The following is a description of a gene set: species: Homo sapiens Expressed lower levels of cartilaginous matrix genes and elevated levels of genes involved in the cellular response to ER stress, namely, DDIT3, HSPA5, and ATF5. Low-grade and medium-grade samples contained Chon2 and Chon1 clusters. Chon1 and Chon2 clusters represent early malignant transformation involving activation of the ER stress pathway. The Chon2 cluster is a marker for the malignant transformation of differentiated tumours (consisting of Ben, Low, and Med). Chon2 cluster markers were enriched in response to ER stress (e.g., DDIT3, HSPA5, and TRIB3). The ER stress response identified in cartilage neoplasm appeared to play a role in the pathological process of tumorigenesis but not in normal skeletal development. The Chon2 cluster accumulated an additional copy number gain at chromosome 19. Thirty-three genes, including UBE2S and TRIM28, showed significant copy number gain at this region. The Chon2 signature score was increased along with tumour grades. Human Gene Set: SU_HO_CONV_CENT_CHONDROSARCOMA_C5_CHON2 from publication Su Z, Ho JWK, Yau RCH, Lam YL, Shek TWH, Yeung MCF, Chen H, Oreffo ROC, Cheah KSE, Cheung KSC (PMID 38267611) The transformation of benign lesions to malignant tumours is a crucial aspect of understanding chondrosarcomas, which are malignant cartilage tumours that could develop from benign chondroid lesions. However, the process of malignant transformation for chondroid lesions remains poorly understood, and no reliable markers are available to aid clinical decision-making. To address this issue, we conducted a study analysing 11 primary cartilage tumours and controls using single-cell RNA sequencing. By creating a single-cell atlas, we were able to identify the role of endoplasmic reticulum (ER) stress in the malignant transformation of conventional central chondrosarcomas (CCCS). Our research revealed that lower levels of ER stress promote chondrosarcoma growth in a patient-derived xenograft mouse model, while intensive ER stress reduces primary chondrosarcoma cell viability. Furthermore, we discovered that the NF-?B pathway alleviates ER stress-induced apoptosis during chondrosarcoma progression. Our single-cell signatures and large public data support the use of key ER stress regulators, such as DNA Damage Inducible Transcript 3 (DDIT3; also known as CHOP), as malignant markers for overall patient survival. Ultimately, our study highlights the significant role that ER stress plays in the malignant transformation of cartilaginous tumours and provides a valuable resource for future diagnostic markers and therapeutic strategies., and this is the list of marker genes: MRPL34, XPOT, COX6B1, PRKAG1, CCND1, GAR1, GDF15, PSMC3, UBXN1, DEDD2, PPM1G, COX14, AAK1, TAX1BP1, KLF5, ARPC5L, ATP6V1E1, GHITM, SCOC, NT5C3A, BUD23, COX5B, PSMD11, UQCRQ, CLTA, NARS1, CTSL, CCT7, NOL7, NDUFB9, SRPRB (SRP receptor subunit beta), THAP7, GTF2F1, RSL24D1, NFE2L1, WDR1, PSMG1, PRR13, CHMP5, RFK, ARL6IP4, REXO4, SSBP1, SERP1, ORMDL2, SPCS1, SNU13, AK6 (adenylate kinase 6), NUDC, SNHG19, PHB2, BEX2, TMBIM6, NDUFA6, TBCB, PSMD7, SLIRP, EIF4A3, AP3D1, EIF5, PHF1, PNO1, PSMA3, TRMT6, BAG1, CCDC107, SEC61A1, TOMM40, TRAPPC2L, MRPL49, GOT1, RND3, METAP2, FKBP4, NOP53, SNF8, COPZ1, EXOSC5, SURF1, DRAP1, HNRNPD, PSMD8, EMC2 (NCBI Gene Id 9694), LENG1, SAP18, NUDT2, PSMD12, MAP2K2, ID4, ATP5ME, TIMM50, EMC4, SLX9, MICOS13, FIBP, CCDC124, GRPEL1, TIMM44, EIF2S1, NDUFS7, ATF5, KIF9 (NCBI Gene Id 64147), SNRPD2, RPL21, HNRNPUL1, MRPL57, RBCK1, SURF2, WSB1, SLC38A1, VTI1B, PCNP, NIBAN1, NDUFA8, TSSC4, TMEM38B (transmembrane protein 38B), SQSTM1, CYCS, PITX1, SERPINE2, SEC11C, NDUFAF3, STRAP, UQCR11, PSMC5, HINT2, ATP5F1D, SLAMF9, PARL, MYLK, CMSS1, SAFB2, IMP3, OTUD6B-AS1, GBE1, C1GALT1, NR1H2, C7orf50, RPA3 (NCBI Gene Id 6119), WBP2, COX7A2L, RPS19BP1, PRDX5, MARS1, RETREG2, DTD1, PSMC4, PRELID1, CREB3, CAMLG, EID1, C11orf58, EIF4B, ZNF667-AS1, REX1BD (required for excision 1-B domain containing), EIF1B, ADRM1, CFAP298, TTC1, CHCHD5, C12orf57, OS9, ARG2, SMIM26, EMC7, POMP, SUPT4H1, PGK1, FAM174C, SEC61G, MMADHC, PRPH, TSPYL2, HSPA9, SEPHS2, TRMT112, NDUFA3, NOSIP, WARS1, UBXN6, DNAJC1, LCN2, EBNA1BP2, MYG1 (NCBI Gene Id 60314), DDX5, SARS1 (seryl-tRNA synthetase 1), RPS5, KRT18, HNRNPM, CITED4, FGF2, UFD1, ZNF593, EIF3K, SF3B2, AATF, UBE2D3, TES, TMX2, IARS1, XRCC6, PA2G4, ATP5PD, EDF1, KARS1, YBEY, THUMPD3-AS1, SMIM7, CCDC85B, GFPT1, AIMP1, GTF2E2, CCT4, POLR2I, SLC25A4, COX17, NDUFAF2, AARS1, STK17A, SNHG25, UBE2V2, LONP1, USP14, UPP1, ERCC1, SRA1, RBM42, BRMS1, MEA1, RRS1, CCNI (cyclin I), PLRG1, KCNG1, CDK4, STOML2, MRPS18C, SHMT2, MIEN1, EMG1, SGTA, H2AJ, CCDC59, NIFK, TMEM147, C9orf78, CHMP2A, SNHG12, CCT6A, PET100, SNRPB2, BNIP3L, SLC25A38, NSFL1C, RPL36AL, CDV3, POLR2C, TNNT1, MRPS12, TNFRSF10B, PSMD14, LARP6, MRPL54